The following is a description of a gene set: The specialization of organization of a photoreceptor, a cell that responds to incident electromagnetic radiation, particularly visible light. An example of this process is found in Drosophila melanogaster. Human Gene Set: GOBP_PHOTORECEPTOR_CELL_DIFFERENTIATION studied in species Homo sapiens, and this is the list of marker genes: DIO3, RPGRIP1L, NR2E3 (NCBI Gene Id 51736), RP1L1, RPGRIP1, USH1C, THRB, PCARE, THY1, NTRK2, CNGB1, BBS10, FAM151B, SAMD11, ELP6, SOX9, IHH, IFT140, RORB, RPGR, BBS1, FSCN2 (fascin actin-bundling protein 2, retinal), SAMD7, TULP1, PDE6C, PRPH2, IFT20, CNTF, GNGT1, NPHP4 (nephrocystin 4), DLX1, CRB2, CEP290, ARL3, VEGFA, MFRP (NCBI Gene Id 83552), ROM1, POC5, NKD1, PPP2R3A, MFSD2A, PRDM1, PRKCI, CFAP418, EPG5, MYO7A, DZANK1, GNAT1, NOTCH1, DLX2, STAT3, AGTPBP1, HCN1 (hyperpolarization activated cyclic nucleotide gated potassium channel 1), TH, PROM1, AHI1, SDK2, DSCAM, NDP, NRL, GNAT2, CABP4, OLFM3, BBS4, PAX6, NAGLU, CDHR1, SOX8, RP1, RAB37, CRB1, TTC8, RDH13